The following is a description of a gene set: Phalangeal dislocation species: Homo sapiens Human Gene Set: HP_PHALANGEAL_DISLOCATION, and this is the list of marker genes: AEBP1, B3GALT6, B4GALT7, COL5A1, CANT1 (NCBI Gene Id 619513), COL1A1 (NCBI Gene Id 4970), COL5A2